Given this list of marker genes PHEX (NCBI Gene Id 5251), CYP2R1, SERPINH1, SLC34A3, COL11A2, CCDC47, CLCN5, NOTCH2, CYP27B1, CILK1, VDR, FGFR3, here is a description of the gene set: species: Homo sapiens A bending or abnormal curvature of the fibula. Human Gene Set: HP_FIBULAR_BOWING Fibular bowing